The following is a description of a gene set: Human Gene Set: WP_TRANSCRIPTION_FACTOR_REGULATION_IN_ADIPOGENESIS studied in species Homo sapiens Transcription factor regulation in adipogenesis, and this is the list of marker genes: INSR, NR3C1, SLC2A4, PCK2, ADIPOQ, CEBPA, RXRA, IRS1, CEBPD, CREB1, IL6, TWIST1, NRIP1, PPARGC1A, CEBPB, MAPK8, FOXO1, IRS2, TNF, LEP, LPIN1, PPARG